The following is a description of a gene set: Any process that stops, prevents, or reduces the frequency, rate or extent of cell death by apoptotic process in hippocampal neurons. Human Gene Set: GOBP_NEGATIVE_REGULATION_OF_HIPPOCAMPAL_NEURON_APOPTOTIC_PROCESS studied in species Homo sapiens, and this is the list of marker genes: CX3CR1, DRAXIN, STAMBP, CX3CL1, LCN2